The following is a description of a gene set: Genes up-regulated in CD4: FOXP3+ T reg versus FOXP3 knockout T reg precursor. Human Gene Set: GSE40685_TREG_VS_FOXP3_KO_TREG_PRECURSOR_UP from publication Samstein RM, Arvey A, Josefowicz SZ, Peng X, Reynolds A, Sandstrom R, Neph S, Sabo P, Kim JM, Liao W, Li MO, Leslie C, Stamatoyannopoulos JA, Rudensky AY (PMID 23021222) species: Homo sapiens Regulatory T (Treg) cells, whose identity and function are defined by the transcription factor Foxp3, are indispensable for immune homeostasis. It is unclear whether Foxp3 exerts its Treg lineage specification function through active modification of the chromatin landscape and establishment of new enhancers or by exploiting a pre-existing enhancer landscape. Analysis of the chromatin accessibility of Foxp3-bound enhancers in Treg and Foxp3-negative T cells showed that Foxp3 was bound overwhelmingly to pre-accessible enhancers occupied by its cofactors in precursor cells or a structurally related predecessor. Furthermore, the bulk of Foxp3-bound Treg cell enhancers inaccessible in Foxp3- CD4+ cells became accessible upon T cell receptor activation prior to Foxp3 expression with only a small subset associated with several functionally important genes being exclusively Treg cell-specific. Thus, in a late cellular differentiation process Foxp3 defines Treg cell functionality in an “opportunistic” manner by largely exploiting the preformed enhancer network instead of establishing a new enhancer landscape., and this is the list of marker genes: IRF1, RNF114, ACSS1, CUL1, B2M, SERPING1, MAP4K3, GBP4, PPP3CC, SNX10, JAK2, DDX60, HESX1, TAP1, KDM6A, IRF9 (NCBI Gene Id 10379), BTN3A3, GRIN3A, STAT2 (NCBI Gene Id 6773), XRN1, HK3, TOE1, USP25, DTNBP1, GIMAP6, BATF2, GIMAP4 (GTPase, IMAP family member 4), ADGRE5, RAPGEF2, OR2T6, OR6S1, PKHD1, CETP (NCBI Gene Id 1071), GRAP, CASP7, RCSD1, BEAN1, TBC1D22A-AS1, LINC00482, TMEM131, NUB1, IFIT2, OAS2, IFI6, GMPR, IFIT3, KPNA3, ZNF572, APOL1, APOL2, ZBTB1, MIR194-2, LYVE1, CIMAP1B, NOS2, MCHR1, CALHM6 (calcium homeostasis modulator family member 6), HLA-F, ASCL2, UBE2L6 (ubiquitin conjugating enzyme E2 L6), MAX, TBX20, SCO2, CARD17P, THEMIS2, ESR1, IFI44L, MOV10, NCOA1, XAF1, CD99L2, GABARAPL1 (GABA type A receptor associated protein like 1), SYP, STAT3, PSMB8, KARS1, AGBL2, APOL6, IFI35, PLAAT4, GUCY1A1 (NCBI Gene Id 2982), SECTM1, DNAJB12, IFIT5, ADAR, ATG3, GCH1, POLB, PSME1, STAT1, TRPM2, TRIM21, ERBB4, KCNMB1, SLC31A2, PIK3R3, PSMB9, HPX, SH3GLB1, RIMKLA, IFITM1, CD2AP, IL17RA, CDK12, MARCHF1, TRANK1, OASL, CASP4, SIK1, EPSTI1, ANKRD22, GBP2, FOXR2, MYH11, PCYT1A, LYG2, RSAD2, MEFV, GOLGA5, SAMD9L, FLT3LG, RTP4, ABI3BP (NCBI Gene Id 79859), SP110, SELENOK, RERE, DPYS, MX1, NLRC5, PPP2R2A, SOCS1, HOXA11, TNFSF10, ASPHD2, HLA-A, IL31RA, SPATA31F2P, CARINH, NPHP4, PANX1, RASGRF1, GK, MNDA, BTN3A2, TAPBP, TRIM22, CD160, VAMP5, CXCL9, TVP23A, CASP1, VPS13C, CNTLN, PIM1, SLC8A1, RNF115, BAZ1A, BTN2A1, NAMPT, PARP14, GUCY1B1, BCL3, IFI27, ACSL4, PIGG, GBP5, RAB12, SQOR, ZNF200, PGK1, PCDHB15, APOBEC3D, WDFY1, ZNFX1, GRIPAP1 (NCBI Gene Id 84538), CALCOCO2, TRAFD1, GIMAP2, JADE2, SMCO4, SART3, HAPLN3, PARP9, PDIA3, RNF19B, AARS1, NFIX, LY6E, NMI, PSME2, FPR1, AIM2, GATA4, ALPK1, FAM8A1, TMEM135, TNFSF13B, PARP12 (poly(ADP-ribose) polymerase family member 12), SEC14L1